Given this list of marker genes Acd, Pot1a, Pif1, Tert, Cdk2, Terf2ip, Dkc1, Nop10, Wrap53, Shq1, Nhp2 (NHP2 ribonucleoprotein), Ankrd28, Gar1, Ppp6c, Terf1, Ppp6r3, Ccna1, Terf2, Ccna2, Rtel1, here is a description of the gene set: Mouse Gene Set: REACTOME_TELOMERE_EXTENSION_BY_TELOMERASE Telomere Extension By Telomerase studied in species Mus musculus